The following is a description of a gene set: Anterior tongue-like protrusions of the vertebral bodies of the lumbar spine. Anterior beaking of lumbar vertebrae Human Gene Set: HP_ANTERIOR_BEAKING_OF_LUMBAR_VERTEBRAE species: Homo sapiens, and this is the list of marker genes: GLB1, GUSB, AGA, FUCA1, GALNS